Given this list of marker genes PLCE1, RRAS, PRKCB, RASA4 (NCBI Gene Id 10156), RASA1, RASGRP4, HRAS, SOS2, PRKCZ, KRAS, LGALS1, RASGRF1, RASGRF2, PRKCA, CAMK2B, SOS1, RASA2 (RAS p21 protein activator 2), RASAL1, PRKCE, RASGRP1, RIN1, GRB2, RASGRP3, RASGRP2, SYNGAP1, RABGEF1, LGALS3, NRAS, NF1, DAB2IP, here is a description of the gene set: from publication Schaefer CF, Anthony K, Krupa S, Buchoff J, Day M, Hannay T, Buetow KH (PMID 18832364) species: Homo sapiens Regulation of Ras family activation Human Gene Set: PID_RAS_PATHWAY